Given this list of marker genes Ghrl, Kit, Ptger4, Scn11a, Kcnma1, Ghsr, here is a description of the gene set: A process in which force is generated within smooth muscle tissue, resulting in a change in muscle geometry in the intestine between the stomach and the large intestine. Mouse Gene Set: GOBP_SMALL_INTESTINE_SMOOTH_MUSCLE_CONTRACTION studied in species Mus musculus